Given this list of marker genes Zdhhc15, Mip, Snapin, Tsc2, Egr3, Pvalb, Ergic1 (endoplasmic reticulum-golgi intermediate compartment 1), Zfp36l2, Psd3, Pde1b, Rps6kc1, Mbd2, Lctl, Mrpl50, Septin6, Znrf1, Fscn1 (fascin actin-bundling protein 1), Ddx4 (NCBI Gene Id 13206), Suox, Irx5, Ppp1r9b, U2af2, Sypl2, Abca5, Plcxd2, Usp50 (ubiquitin specific peptidase 50), Pea15a, Cyp1b1, Phc2, Zfp703, P2ry10, Hoxb3, Pakap, Rnf151, Sin3a, Scg2, Pla2g7, Pinx1, Ywhag, Dhdh, Glt8d1 (NCBI Gene Id 76485), Lgals9, Nipal2, Zdhhc9, Nos1, Mb21d2, Lhx6, Pglyrp4, Kcnj6, Rgs7, Col1a1, Hsd3b1, Cxcl12, Ppp2r1b, Sox6, Pbx2, Gzmb, Samd4b, Hnrnpab (NCBI Gene Id 77086), Itsn1, Fgfr4, Runx2, Maco1, Slc41a1, Csnk1g1, Sclt1, Emilin3, Zfp955a, Casq1 (calsequestrin 1), Nup35, Fzd10, Nova2, Pgrmc2 (NCBI Gene Id 70804), Nfix, L1td1, Eda2r, Smco1, Atf2, Fam163b, Cert1 (ceramide transporter 1), Bloc1s5, Prr12, Sncb, Clns1a, Ccl27a, Phyh, Trim67, Tomm34, Dclk1, Arhgap6, Lipm, Rbpj, Gnas, Tex26, Popdc3, Megf9, Ddx17, Gnrhr, Grm4 (NCBI Gene Id 268934), Zfp709, Mink1, Stc1, Tbc1d30, Alx4, Plekhf2, Hoxb5, Slc8a3, Ctnnd1, Wasf1, Slc22a27, Wnt9b, Slc18a1, Atxn1, Pknox2, Fst, Dcx, Stk17b, Tsku, Sel1l3, Ubqln3, Kcna1, Dpf2, Aff1, Ccl12, Plch1, Pa2g4, Cartpt, Alkbh1, Gem, Btn2a2, Hoxd11, Ksr1, Cyp2u1, Srgap3, Wbp1l, Glyctk, Stum, Tceanc2, Usp46, Bcl11b, Ramp1, Mog, Sox11, Inhbb (inhibin beta-B), Csta1, Zfp646, Pou3f2, Cbx6, Smap2, Kmt2a, Gng11, Scap, Nt5dc1, Khsrp, Cacna1e, Atg7, Nfasc, Ccdc68, Zfhx2, Sfxn1, Marcksl1, Cln6, Pld6, Dlgap3, Mttp (microsomal triglyceride transfer protein), Ptpn3, Akr1c20, Hecw2, Zfp119a, Irf2bp1, Tmem63a, Mex3a, Gspt1, Atat1, Slc6a17, Mblac2, Jchain, Prkn, Spata31, Pcdhga6 (protocadherin gamma subfamily A, 6), Stk26, Trim71, Qser1, Arhgap26, Aph1a, Lama3, Tdrd3, Lcorl (ligand dependent nuclear receptor corepressor-like), Dglucy, Prss33, Cd7, Tln2, Pef1 (NCBI Gene Id 67898), Cobl, Shisa9, Krtap4-7, Plagl2, Arid2, Smap1, Zfp865, Jade1, Gng12, Lrrc3b, Hip1, Atf7, Zfp84, Glmp, Nek8, Ubr4 (ubiquitin protein ligase E3 component n-recognin 4), here is a description of the gene set: studied in species Mus musculus from publication Chen Y, Wang X (PMID 31504780) Genes predicted to be targets of miRBase v22 microRNA mmu_miR_7073_5p in miRDB v6.0 with MirTarget v4 prediction scores > 80 (high confidence targets). Mouse Gene Set: MIR_7073_5P